The following is a description of a gene set: species: Homo sapiens The aggregation, arrangement and bonding together of a set of components to form a podosome, an actin-rich adhesion structure characterized by formation upon cell substrate contact and localization at the substrate-attached part of the cell. Human Gene Set: GOBP_PODOSOME_ASSEMBLY, and this is the list of marker genes: KIF9 (NCBI Gene Id 64147), MAPK9, RHO, HCK, BIN2, CSF2 (NCBI Gene Id 1437), GSN, RHOA (NCBI Gene Id 387), SRC (NCBI Gene Id 6714), IL5, MSN, DIAPH3, DOCK5, FARP2, LCP1, ARHGEF5, DBNL, TNF, ASB2, FSCN1, SH3PXD2B, CAPG